The following is a description of a gene set: from publication Gross C, Dubois-Pot H, Wasylyk B (PMID 17704799) species: Mus musculus The ternary complex factor Net/Elk3 is downregulated in hypoxia and participates in the induction by hypoxia of several genes, including c-fos, vascular endothelial growth factor and egr-1. However, the global role of Net in hypoxia remains to be elucidated. We have identified, in a large-scale analysis of RNA expression using microarrays, more than genes that are regulated by Net in hypoxia. In order to gain insights into the role of Net in hypoxia, we have analysed in parallel the genes regulated by HIF-1alpha, the classical factor involved in the response to hypoxia. We identified about genes that are regulated by HIF-1alpha in hypoxia. Surprisingly, when we compare the genes induced by hypoxia that require either Net or HIF-1alpha, the majority are the same (75%), suggesting that the functions of both factors are closely linked. Interestingly, in hypoxia, Net regulates the expression of several genes known to control HIF-1alpha stability, including PHD2, PHD3 and Siah2, suggesting that Net regulates the stability of HIF-1alpha. We found that inhibition of Net by RNAi leads to decreased HIF-1alpha expression at the protein level in hypoxia. These results indicate that Net participates in the transcriptional response to hypoxia by regulation of HIF-1alpha protein stability. Genes up-regulated in SEND cells (skin endothelium) at normal oxygen (normoxia) conditions after knockdown of HIF1A by RNAi. Human Gene Set: GROSS_HIF1A_TARGETS_UP, and this is the list of marker genes: F2R, TCF7L1, C3, MRO, DDR2, MAFB, TLR2